The following is a description of a gene set: Receptor Interacting Serine/Threonine Kinase 1 (RIPK1)-mediated regulated necrosis also called necroptosis is an important type of programmed cell death in addition to apoptosis. Necroptosis eventually leads to cell lysis and release of cytoplasmic content into the extracellular region. Necroptosis must be tightly controlled. Disregulated or defective necroptotic cell death is often associated with a tissue damage resulting in an intense inflammatory response. Defects of necroptosis may contribute to various pathological processes, including autoimmune disease, neurodegeneration, multiple cancers, and kidney injury. Reactome Pathway: Defective RIPK1-mediated regulated necrosis part of: Diseases of programmed cell death studied in species Homo sapiens, and this is the list of marker genes: OPG199, RIPK3, NS, RIPK1, FADD (Fas associated via death domain), 3a, TRAF2, RIR1, CASP8, MLKL, UL36, TRADD